The following is a description of a gene set: Genes predicted to be targets of miRBase v22 microRNA mmu_miR_7683_5p in miRDB v6.0 with MirTarget v4 prediction scores > 80 (high confidence targets). studied in species Mus musculus Mouse Gene Set: MIR_7683_5P from publication Chen Y, Wang X (PMID 31504780), and this is the list of marker genes: Apol9a, Mapk1, Trappc9, C2, Vangl2, Apol9b, Ankrd17, Bcl6, Pan3, Map3k5, Lmo7, Lins1 (NCBI Gene Id 72635), Nedd1, Fkbp5